The following is a description of a gene set: studied in species Homo sapiens Human Gene Set: GOBP_REGULATION_OF_MAINTENANCE_OF_SISTER_CHROMATID_COHESION Any process that modulates the extent to which the association between sister chromatids of a replicated chromosome is maintained., and this is the list of marker genes: MACROH2A1, ATRX, SLF2, SMC5, TNKS, NSMCE2, BUB1, NAA10, SLF1